Given this list of marker genes Ctsk, H2-K1, Creg1, Tmem9b, Spag9, Kif5b, Rraga, Ap1b1, Snx14, Prkcd, Cyb561, Fuca2, Chmp3, Pld3, Tmem79, Ctsr, Scarb1, Adam8, Ppt1, Ap5z1, Tpp1, Wdr24, Slc17a9, Syt7 (NCBI Gene Id 78663), Litafd, Cts7 (cathepsin 7), Chmp5, Snx2 (sorting nexin 2), Lgmn, Cd63, Tinagl1, Myo5a, Rheb, Marchf8, Marchf1, Ifitm1, Flcn, Mt1, Nbr1, Ocln, Ncstn, Cts6, Rnf19b, Hps6, Elapor1, Gzmc, Dpp7, Pla2g5, Lrrc8e, Hgs (NCBI Gene Id 21921), Ctss, Rragb, Npc1, H2-D1, Arl8b, H2-Aa, Shkbp1, Ap1s2, Grin2b, Cltc, Plaat3, Atp6v0d1, Nos1, Cst7, Arsg, H2-T22, Arsb, Abcd1, Slco2a1, Cd1d2, Dram1, Epg5, Ap1g1, Gzmg, Cd164, Galns, Cd300ld3, Atp6v1a, Il1b, Cybrd1, Rab7, Cts3, Uba1, Defa42, Ctsw, Grn (granulin), Bbc3, Chit1 (chitinase 1), Abcb6, Marchf2, Hck (NCBI Gene Id 99093), Mpo, Sidt1, Napsa, Tcirg1, Trim29, Kxd1, Ifitm2 (interferon induced transmembrane protein 2), Fth1, Lrba, Dtx3l, Has2, Ctsj (cathepsin J), Lamtor2, Mgat3, H2-Eb1 (NCBI Gene Id 406211), Plekhm1, Cln5, Laptm5, Clnk, Cxcr2, Sar1b (secretion associated Ras related GTPase 1B), Tsc2, Ctsf, Cryab, Siglecf, Gpr137, Lipa, Irgm1, Lamp1, Lamtor4, Oca2, Ap5m1, Lamp2, Tmem203, C9orf72, Chmp7, Col6a1, Wdr81, Stxbp2, Ace, Prdx6, H2-Oa, Sesn2, Rictor, Snapin (NCBI Gene Id 99847), Il4i1, Tmem175, Bcl10, Ank2, Atp10b, Snx1, Dnase2b, Gpr143, Laptm4b, Borcs8, Vps39, Anxa2, Vamp8, Dnase2a, Kcnq1, Prcp, Cyb561a3, Tmem45b, Rab27a, App, Anxa6, Tm9sf1, Wdr83, Akr1b8, Gfap, Itfg2, Minar2, Gpr137c, Cd68, Ctsg, Prf1, Bace1, Snx6, Ctsh, Akr1b1, Zfyve26, Arrdc3, Ffar4, Tmem165, Mfsd1, Pla2g10, Atp6ap2, Wwox, Calcrl, Hap1, Plekhf1, Sidt2, Ap1m1, Hexb, Npc2 (NPC intracellular cholesterol transporter 2), Mcoln2, Tsc1, Mlc1, Ifnar1, Pik3c3, Bloc1s1, Fnip1, Deptor, Mcoln3, Slc15a4, Lamtor3 (NCBI Gene Id 99927), Unc13d, Ggh, Rnf152, Sec13, Ctbs, Trim23, H2-DMb2, Map1lc3b, Plekhm2, Chmp1b, Slc30a2, Rab8a, Nkg7, Mitf, Tmem150c, Tial1, Naga, Hyal4, Slc46a3, Nsg2, Hsp90ab1, Galc, Tmem97, Unc93b1, Tmem106b, Ankrd27 (ankyrin repeat domain 27), Sort1, Tfeb, Ftl1, Zp3r, Plaat1, Fcmr, Itm2c, Tmbim1, Fuca1, Rab38, Tmem199, Bri3, Doc2a, Calr, Trim17, Akr1b10, Tpcn1, Abca3, Rragc, Trpv3, Ctsq, Nppa, Gzmd, Pip4p2, Slc39a14, Marchf9, Myo7a, Rab14, Mios, Vps41, Crhbp, Cts8, Ear14, Glb1, Rnf183, Slc11a2, Bloc1s2, Tm4sf5, Acp5, Dram2 (NCBI Gene Id 99690), Arl8a, Snap23, Gnptg, Slc3a2, Sqstm1, Anxa11, Vps13c, Chmp1b2, Lamp5 (NCBI Gene Id 76161), Tlr7, Tbc1d7, Cdip1, Tasl, Slc2a13, Srgn, Spns1, Tm6sf1 (transmembrane 6 superfamily member 1), Mcoln1, Slc31a2, Lamp3, H2-DMb1, Rnaset2a, Kif2a, Traf3ip3, Mtor, Mfsd8 (major facilitator superfamily domain containing 8), Defa39, Abhd6, Fnbp1, Vps33b, Cxcr4, Nprl2, Lrrc8a, Tmem63a, Slc7a14, H2-M2, Marchf3, Sgsh, Kics2, Spata31, M6pr, Pcyox1, Prtn3 (proteinase 3), Rragd, Mlst8, Litaf, Naaa, Pld4, Slc12a9, Ctsl, 4930486L24Rik, Tnfaip3, Vti1b, Hyal2, P2rx4, Ada, Fasl, Tab2, Ank3, Znrf1, Atp6v1g1, Rab9b, Rab3a, Prmt1, Mfsd12, Kcmf1 (potassium channel modulatory factor 1, NCBI Gene Id 74287), Pla2g15, Scarb2, Serpinb1a, Ap1s3, Psen1, Ube2a, Rnase6, Slc49a4, H2-Ob, Rptor, Borcs6, Meak7, Aga, Slc15a3, Vps35, Slc39a8, Slc17a5 (solute carrier family 17 (anion/sugar transporter), member 5), Defa20, Dbndd2, Depdc5, Cd74, Snx16, Prss57, Gns, H2-M10.2, Man2b2 (mannosidase 2, alpha B2), Slc11a1, Sppl2b, Lars1, Gga3, Chmp6, Syt11, Fyco1, Neu4, Acp3, Ncoa4, Vps26a, Chid1, Ctsb, Ppt2, Gzmb, Rnf13, Slc35f6, Abca2, Naglu, Gba1, H2-Q6, Capn2, Psapl1, Neu2, Ctsz, Borcs7, Tmem192, Ostm1, Trpm2, Rps6kc1, Tmem163, Rab9, Ctsm, Man2b1, Gpc3, Rb1cc1, Tpcn2, Rab12, Seh1l, Gimap5 (GTPase, IMAP family member 5), Nsg1, Cubn, Gm2a, Rmc1, Acp2, Tecpr1, Idua, Sting1, Stx3 (NCBI Gene Id 20908), H2-M11 (histocompatibility 2, M region locus 11), Mreg, Pip4p1, Capn1, Slc38a9, Ctsll3, Ctso, Plbd1, Arsk, Hyal1, Lamtor1, Psap, Trip10, Hyal3, H2-M10.6, Kptn, Slc37a3, Anxa1, Atraid, Hps4, Wdr48, Rnaset2b, H2-M5, Ctsc, Hexa, H2-Eb2, Vps4a, Vps18, Sftpb, Lrrk2, Slc36a4, Clcn4, Gusb, Gzme, H2-M10.4, Pla2g4e, Gla, Map1lc3a, Ctsa, Rubcn, Hspa8, H2-Ea, Znrf2, Abca5, Neu1, Hgsnat, Gabarap, Slc30a3, Pip4k2a, Chmp2b, Ap1s1, Acp4, Vma21, Neu3, Hpse, Stx8, Slc48a1, H2-DMa, Tspan1, Klhl22, Vopp1, Arsa, Mmd, Manba, Sphk2, Entpd4, Tinag, Clcn3, Slc7a5, B2m, Tpsab1, Cpq, Cln3, Src, Fnip2, Rab7b, Klc2, Treml4, Atp13a2, H2-M10.1, Lmbrd1, Slc26a11, Ldlr, Siae, Ctsd, Slc29a3, Laptm4a, Insr, Lamtor5 (NCBI Gene Id 68576), Slc2a6, Slc9b2, Clec16a, Szt2, AY761185 (NCBI Gene Id 503556), Gzmf, Mapkap1 (mitogen-activated protein kinase associated protein 1), Cd34, Chmp4c, Pgap6, Abcb9, Pdgfrb, Plbd2, Sppl2c, Ids, Dnm1l, Pde1c, Defa43, Wdr59, Ifitm3, Gpr155, Atxn3 (ataxin 3), Abcd4, Tnfaip8l2, Ifi30, H2-Q2, Defa38, Pcsk9, Gzmn, Tmem9, Spaar, Rab10, Rnf167, Vps36, H2-Ab1, Defa32, Slc30a4, Vps13b, Tfe3, H2-Q7, Mpeg1, Slc36a1, Sppl2a, Cd1d1, Slc66a1 (NCBI Gene Id 212555), Tmem25, Vps13a, Vps33a, Vps16, Rilp, Uvrag, Chmp2a, Chmp1a, Ifitm7, Ubxn6, Borcs5, Sod1, Fgfr3, Glmp, Prss16, Tmem74, Tlr9, Smpd1, Tlr8, Ramp3, Akr1b7, Clcn7, Tmem59, Ccdc115, H2-Q1, Gaa, Atg16l1, Sar1a, Ctns, H2-Q10, Wdr45b, Pfpl, Sult1c2, Gpr137b, Asah1, Nprl3, Chmp4b, Stx7, Eva1a, Vps11, Irgq, Slc38a7, Rab39, Spaca7, Ap5s1, Ccz1, BC051665, Epdr1, here is a description of the gene set: Mouse Gene Set: GOCC_LYTIC_VACUOLE A vacuole that is maintained at an acidic pH and which contains degradative enzymes, including a wide variety of acid hydrolases. species: Mus musculus